Given this list of marker genes Pax8 (paired box 8), Pax2, Pkd1, Calb1, Pou3f3, Pkd2, Umod, here is a description of the gene set: The process whose specific outcome is the progression of the metanephric distal tubule over time, from its formation to the mature structure. The metanephric distal tubule is a metanephric nephron tubule that begins at the metanephric macula densa and extends to the metanephric connecting tubule. studied in species Mus musculus Mouse Gene Set: GOBP_METANEPHRIC_DISTAL_TUBULE_DEVELOPMENT